Given this list of marker genes Dipk2a, Nfe2l2, Pcmt1, Rapgef3, Erbb4, Nupr1, Edn1, Arrb2 (NCBI Gene Id 216869), Sirt1, Lrp6, Hspb6, Sirt5 (NCBI Gene Id 69760), Stub1, Ppp1r10, Sfrp2, Mdk, Nol3, Kifap3, Atg5, Qki, Npm1, Alox12, Zc3h12a, Slc7a5, Igf1, Pdpk1, Hsf1, Adcyap1, Gapdhrt2, Cftr, Gsk3b, Igf1r, Gch1, Tbx1, Pik3r1, Myocd, Nrg1, Notch1, Cav1, Cflar, Gapdh, Ambra1, Gata4, Lypd3, Lifr, Sirt4, Hspa8, Dnmt1, Agtr1a, Acot1, Hmox1, Hey2, Mapk7, Ghrh, Apoh, Hmgcr, Hand2, Gapdhrt, Ilk, Atg7, Slc25a4, Jak2, Pax8, Nr4a3, Mfn2, Ptk2b, Bcl2, Map2k5, Gria4 (NCBI Gene Id 56510), Trip10, Nkx2-5, Bag3, Esr1, Rgl2, here is a description of the gene set: species: Mus musculus Mouse Gene Set: GOBP_NEGATIVE_REGULATION_OF_MUSCLE_CELL_APOPTOTIC_PROCESS Any process that decreases the rate or frequency of muscle cell apoptotic process, a form of programmed cell death induced by external or internal signals that trigger the activity of proteolytic caspases whose actions dismantle a muscle cell and result in its death.